The following is a description of a gene set: from publication Chen Y, Wang X (PMID 31504780) species: Homo sapiens Human Gene Set: MIR877_5P Genes predicted to be targets of miRBase v22 microRNA hsa-miR-877-5p in miRDB v6.0 with MirTarget v4 prediction scores > 80 (high confidence targets)., and this is the list of marker genes: LMAN1, POU2F1, OCSTAMP, ALDH5A1, C14orf119, NME4, ANO6, GRK2 (G protein-coupled receptor kinase 2), DYRK1A, C4orf33, TDRD1, DPY30, PANK3, MAP7D3 (NCBI Gene Id 79821), FXR2, ZNF264, ATP2B1, GLDC, VGLL3, CEP350, ELF1, FSD1L, BAZ1A, SORBS3, ATP11B, UBN2, GNB4, FGB, OSTC, DEPDC4, ZC3H12B, TP53INP2, CNTN3, LMBRD1, C15orf40, CDO1, CSNK1G3, E2F5, ZKSCAN2, C5orf47, PLEKHB1, HELQ, GALR1, ASTN2, KRTAP4-9, TTC14, SKA2, CTBS, TRIM10, YLPM1, KTI12 (NCBI Gene Id 112970), ETFRF1, ITM2B, ZNF174, COL6A3, ADAMTSL1, HOXA10, RDX, ZFYVE26, STYK1, PHF8, ESRP1, PDE1C, BTD, CDKN1B, METTL13, KRTAP4-8, ANKFY1, KRTAP4-11, ATE1, LOX, CDC40, FOXD4L5, HLA-DRA, DDO, BTN1A1, TLL2, EPDR1 (ependymin related 1), GFOD2, POLQ, CFHR5